Given this list of marker genes HSD17B7, DHRS4, HSD3B1 (hydroxy-delta-5-steroid dehydrogenase, 3 beta- and steroid delta-isomerase 1), DHRS11, CBR3, here is a description of the gene set: Human Gene Set: GOMF_3_BETA_HYDROXYSTEROID_3_DEHYDROGENASE_NADPPLUS_ACTIVITY Catalysis of the reaction: a 3-betahydroxyl sterol + NADP+ = a 3-oxosterol sterol + NADPH + H+. studied in species Homo sapiens